Given this list of marker genes ALDH3B2, MBTPS1, ACER1 (alkaline ceramidase 1), TKFC (NCBI Gene Id 26007), INPP4B, SCARB1, NUDT3, PTH (parathyroid hormone), APOL1, ANGPTL3, OCRL, FKRP, DHCR7, SEC14L2, DHFR, MOGAT3, PPIP5K1, AKR1C4, CLN6, GOT1, PPARD, IPMK, RDH5, SGPP2, IP6K1, PLPP1, NR1H4 (NCBI Gene Id 9971), NUDT4, APOA4, PRKAA1, RDH10, DHRS4, ACSS2, CD244, LEPR, BMP6, DPM3, CEL, LDLRAP1, AKR7A2, ADH1B, AKR1B10, ADH1C, SREBF2, MIR548P, ALDH3B1, GALK1, DGAT2, GCH1 (NCBI Gene Id 93984), IL4 (NCBI Gene Id 3565), FGFR1, PLCB1, APOF, FGF1, DBH, TPK1, ALDH3A2, DGAT1, SULT1C3, LIPA, PLPP3, STARD4, MIR96, APOB, G6PD, PRKAA2, CES1, HMGCS2, DHCR24, SPTLC2, ITPK1, PTS, IDH3B, SQLE, CYP2C9, ITPKB, GPD2, LRP2, SYNJ1 (synaptojanin 1), MAPK1, PLA2G4A (NCBI Gene Id 5321), FMO5, QKI, IP6K2, SGPP1, MIR27A, PLB1, CFTR, TSKU, SORD, ITPKC, CETP, EPHX2, CYP2C18, HMGCR, STAR, THTPA, AGT, MIR342, PCSK9, IP6K3, DEGS2, PTH1R (parathyroid hormone 1 receptor), SCARF1, ALDH2, GNB3, APOA1, EBP, CYP11B1, GBA2, C7orf50, APOC1, RPE65, DISP3, NSDHL, AKR1D1, SPR, LDLR, DGKQ, MOXD1, PNLIP, LHCGR, SMPD1, NAAA, CYP1A1, SLC34A1, ADH6, ASAH2, DHRS3, ADH1A, ABCG1, DAB2 (DAB adaptor protein 2), DHRSX, BMP2, CYP27B1, P2RY6, CYP51A1, HMGCS1, CYP3A5, ADH4, INPP5B, COQ2, SPTLC1, CYP11B2, RDH12, ALDH1A3, FDFT1, PNPLA4, PECR, SPTSSB, DHFRP1, CYP3A7, PIP4P1, APOE, LPCAT3, IMPA2, SULT2A1, HSD17B7, NPC1L1, AQP8, PLEK, CYB5R3, TKTL1, ACSS1, APOA5, PRKG1, LRAT, NUS1, MOGAT2, IGF1, RDH14 (NCBI Gene Id 57665), LRP5, HAO1, DOLK, SPHK1, MVD, MECP2, ADH7 (alcohol dehydrogenase 7 (class IV), mu or sigma polypeptide), PTAFR, BMP5, SULT1B1, PLCG2, H6PD, AKR1B15 (NCBI Gene Id 442622), SOAT2 (sterol O-acyltransferase 2), DHDDS, CYP46A1, IDI2, SRD5A3, LSS, ACAA2, CH25H, SULT1C4, CACNA1H, ACP3, WNT4, FECH, NTSR1, CYP2C8, CUBN, GK, ACER2, CEBPA, NUDT11, IDH2, SULT1E1, QDPR, ASAH1, LIPC, SPTLC3, INSIG1, GBA1, NAPEPLD, CYP1B1, AKR1C2, GALR2, TM7SF2, CYP27A1, RDH16, GDPD1, SNX17, LIPE, MOGAT1, AKR1B1, AVPR1B, CYP2R1, P2RY1, PCK1, CLN8, MIR30C1, ACER3, MVK, BCO1, AKR1A1 (aldo-keto reductase family 1 member A1), LIMA1, AKR1C1, IMPA1, SULT1A2, GDE1, GPER1, NPC1, LCAT, INSIG2, MIR182, PMVK, PCBD2, GDPD3 (NCBI Gene Id 79153), MINPP1, ERRFI1, FDPS, EDNRB, CYP2D6, PGP, CYP3A4, NR0B2, SCP2, SULT2B1, GK2, MBTPS2, PPIP5K2, PNPLA2, ACLY, PON1, SCNN1B, INPP5A, CYP27C1, AGK, MIR27B, ALDH1B1, GNAI1, PRKACA, SERPINA12, PCK2, SDR16C5, LEP, IDH3A, COQ3 (NCBI Gene Id 96592), CYP1A2, ALDH1A1, ARV1, PRKG2, INPP4A, TTC39B, APOL2, UGT1A3, AWAT2, APOA2, IDH3G, HSD11B2, DHRS7, NUDT4B, CYP39A1, ABCG4, RDH8 (NCBI Gene Id 50700), DPM2 (NCBI Gene Id 8818), ABCA5, ERLIN2 (NCBI Gene Id 140906), PARK7, KPNB1 (NCBI Gene Id 3837), ALDH1A2, PAQR3, ISYNA1, RBP4, GK5, NPC2, DPM1, HSD17B6, SLC5A3, CYP11A1, APOBR, RETSAT, DHRS9, ABCA1, SULT1A4, SNCA, ACADL, LBR, SC5D, SPHK2, STARD3, IDI1, SULT1A3, DKK3, OSBPL5, REST, PLPP6, RDH13, PCBD1, AKR1C3, ABCA2, UGT1A4, ITPKA, MIOX, AGTR1 (angiotensin II receptor type 1), CLCN2, CYP24A1, INPP5J, NUDT10, SOAT1, CAT, HDLBP, OSBPL1A (NCBI Gene Id 55097), NFE2L1, SPTSSA, NOS3, GPR146, ACADVL, MOXD2P, MSMO1, RDH11, FDX1, IPPK, SREBF1, FDXR, SULT1A1, SCAP, CYP7B1, ERLIN1, MIR185, TPI1, VLDLR, CBR4, ADCYAP1R1 (NCBI Gene Id 117), SDR9C7, LMF1, MIR98, CYP7A1, PLPP2, IDH1, here is a description of the gene set: Human Gene Set: GOBP_ALCOHOL_METABOLIC_PROCESS species: Homo sapiens The chemical reactions and pathways involving alcohols, any of a class of compounds containing one or more hydroxyl groups attached to a saturated carbon atom.